The following is a description of a gene set: Primary microcephaly Head circumference below 2 standard deviations below the mean for age and gender at birth. studied in species Homo sapiens Human Gene Set: HP_PRIMARY_MICROCEPHALY, and this is the list of marker genes: RNF2, CEP295, SPOP, SLC16A2, SMC3, ZNF335, EIF5A, CTNNB1, LMNB2, IFIH1, FIG4, CIT, TBL1XR1, PDCD6IP, SLC25A19 (NCBI Gene Id 60386), LAGE3, YRDC, AFG2A, SASS6, CENPE, ZEB2, CDK5RAP2, AFF3, NSF, TXN2, SLC1A4, FZR1, TSEN54, TUBB3, VAC14, PCDH12, KAT6A, RNU4-2, RBBP8, NUP37, TRMT10A, TRIO (NCBI Gene Id 7204), NUP188, ASNS, KATNB1, RELN, FRMD4A, PPFIBP1, NDE1, ANKLE2, COASY, CDK6, CEP63, NCAPD2, VPS4A, KNL1, ARHGEF2, MECP2, EOMES, STIL, TELO2, TP53RK, DTYMK, DYRK1A, TBCD, SLC25A12, IARS1, BUB1, PSAT1, COG7, PHGDH, IER3IP1, PPP1R15B, TRAPPC12, MCPH1, CLPB, CEP135, TPRKB, TRAPPC14, TUBB, GRIN2A